Given this list of marker genes CRP, PRKAG3, ACLY, MAPK9, ACACB, G6PC2, PRKAG1, MAPK1, MAPK3, MAPK8, MAPK14, G6PC1, HMGA1, PCK2, SLC27A2, PRKAB1, PRKAA2, MAPK13 (mitogen-activated protein kinase 13), MAPK10, PRKAA1, PRKAB2, PRKAG2, G6PC3, MAPK11, MAPK12 (NCBI Gene Id 6300), ACACA, here is a description of the gene set: Human Gene Set: WP_BEMPEDOIC_ACID_THERAPY_IN_ATHEROSCLEROSIS_AND_METABOLIC_SYNDROME studied in species Homo sapiens Bempedoic acid therapy in atherosclerosis and metabolic syndrome